The following is a description of a gene set: species: Homo sapiens Human Gene Set: chr10q21, and this is the list of marker genes: JMJD1C, SNORD98, LINC02672 (long intergenic non-protein coding RNA 2672), FAM13C, ALDH7A1P4, RPL7AP50, SLC25A16, MRPL50P4 (NCBI Gene Id 359751), CCAR1, RTKN2, LRRTM3, RNU6-1250P, CISD1, MIR7151, MYPN, LINC00844, PRELID1P3, RPL17P35, COX20P1, ATOH7, LINC00845, LINC01553 (NCBI Gene Id 283025), FAM133CP, ANK3-DT, MIR3924, BICC1, THAP12P3, ZNF365, TMEM14DP, LINC02671, TPT1P10, RNU2-72P, ANK3, RPL7AP51, DNA2, ENSG00000228566, ENSG00000288011, JMJD1C-AS2, RN7SL394P, HNRNPH3, CTNNA3, MYL6P3, DNAJC12, RPL12P8, RPL26P29, RPS3AP37, SNRPEP8 (SNRPE pseudogene 8), ARL4AP1, ENSG00000287016, MRPS35P3, LINC02625, RNA5SP319, RNA5SP318, CABCOCO1 (ciliary associated calcium binding coiled-coil 1), LINC02640, SLC16A9, ENSG00000238707, RPL31P44, POU5F1P5, RN7SL591P, LNCAROD, RN7SL220P, IPMK, MIR548F1, NEK4P3, RPS3AP38, MIR605 (NCBI Gene Id 693190), MRPL35P2, ENSG00000273360, PBLD, LINC02621, MRLN, ANXA2P3, RPLP1P10, RUFY2, DBF4P1, PHYHIPL, HERC4, KRT19P4, SIRT1, RPL21P92, DKK1, TATDN1P1, EGR2, UBE2D1, NEFMP1, TRAF6P1, MIR1296 (NCBI Gene Id 100302150), RPL26P27, TMEM26-AS1, ADO, NRBF2, RSU1P3, TMEM26, RNU6-543P, TFAM, JMJD1C-AS1, CSTF2T, PCDH15, CDK1, AKR1B10P1, RNU6-523P, RN7SKP202, RHOBTB1, LINC02929, CCEPR, ZWINT, TET1, CCDC6, RN7SKP196, PRKG1-AS1, ENSG00000234173, RNU6-687P, DNAJC19P1, CYP2C61P, ARID5B, GAPDHP21, LINC01515, REEP3, MBL2, ENSG00000289989